Given this list of marker genes PTPN2, MOB3B, CCDC169, HIVEP3, LZTFL1, GLYCTK, CCRL2, DCAF13, RRAS2, TCERG1, CLIC4, CSNK1A1 (casein kinase 1 alpha 1), RNPC3, CACNB3, BTC, SSPOP, FAM98B, MAPK6, STX11, CENPH, SNN, ADM, PRR5L, FILIP1L, ARID5A, HCAR2, NOCT, TET2, PPP1R15B, OPTN, PPFIBP1, VPS54, ACOT9, SLC30A6, HSPA13, GNA13, MAPKAPK3, SLC39A8, LANCL2, CA13, TCP11, SPRYD7, CEMIP2 (cell migration inducing hyaluronidase 2), SMIM3, IL12B, SFPQ, LCAT, RND1, STARD7, INHBB, TPGS2, CREBL2, HDC, PIM1, CNPPD1, PRKX, MGAT4A, CTRB2, GTF2B, TMEM243, RRP15, AFF1, TMBIM1, ZFP36, REL, BEX3, VAPA, CD14, SLAMF1 (signaling lymphocytic activation molecule family member 1), EZR, C19orf33, INTS12, PSD3, WAC, PSD, JDP2, FURIN, ZC3H12A, RYBP, KREMEN1, ESF1, DNAJC21, SLC39A14, MATN3, NOL10, LSP1, ARHGAP26, TLE1, ACKR3, PLAUR, DOCK3, FLT1, RNF148 (ring finger protein 148), MTPAP, DCUN1D3, EIF3J, FZD7, PGS1, TTC19, DHX15, P2RY2, LRCH1, RHOU, HARS1, TMEM88, KXD1, NFKBIL1, NFKBIB, EDN1, YTHDC1, KCNIP4, DUSP16, EFNA2, IL17RA (interleukin 17 receptor A), CBLN2, PLAGL2, NCK1, PEMT, OAF, STAT5A, WDR59, RNF180, ETV3, CH25H, SPATA13, KPNA3, TEX12, IPO5, RFFL, LSR, STIP1, JARID2, AEBP2, EXOC3L4, MYCL, FANCM, STX6, KLF6, NFIL3, RAP2C, SRC, RCAN1, SEH1L (SEH1 like nucleoporin), TIAL1, RAD54B (RAD54 homolog B), APPL1, PAM, PPP1R14C, SLC30A4, SYNE3, MICU3, ITGAV, CX3CL1, STYX, IL4I1, IER2, G3BP1, FCHSD2, CSRNP1, BTF3, FGF9 (fibroblast growth factor 9), SLC4A7, SLC2A6, RBM22, MAP3K5, HNRNPA2B1, DR1, SPINT2, RIPK2, MED13L, RBIS, LTV1 (NCBI Gene Id 84946), SPRED1, FANCC, C2orf76, BRIX1, INO80, MYH11, CDV3, NOP56, LGI4, MTERF3, PFKFB3, SEMA4C, RSRC2, SLC12A4, PDCD10, RHBDF1, CD83, MTDH, MAPKBP1, ZFAND5, TRIM36, TFEC, VCAM1, KIN, SPHK1 (sphingosine kinase 1), ADAMTS4, PDE4B, RBMXL1, here is a description of the gene set: from publication Ochiai K, Maienschein-Cline M, Simonetti G, Chen J, Rosenthal R, Brink R, Chong AS, Klein U, Dinner AR, Singh H, Sciammas R (PMID 23684984) Human Gene Set: GSE46606_IRF4MID_VS_WT_CD40L_IL2_IL5_DAY3_STIMULATED_BCELL_UP species: Homo sapiens Temporal analysis of B cell activation in vitro using CD40L and IL-2/4/5 cytokines in wild type Irf4+/+ B cells or in mutant Irf4-/- B cells harboring a tet-inducible allele of Irf4. IRF4 expression was restored, or not, in the Irf4-/- background by culturing in the presence of low or high concentrations of doxycycline. The results provide insight in the role of IRF4 expression levels in coordinating different programs of B cell differentiation. Genes up-regulated in CD40L and IL-2 IL-4 IL-5 stimulated at day 3 B cell IRF4intermediate versus CD40L and IL-2 IL-4 IL-5 stimulated at day 3 B cell wildtype.